Given this list of marker genes CHUK, TRAF2 (TNF receptor associated factor 2), NFKBIA, IKBKB, NFKB1, RELA, IKBKG, here is a description of the gene set: Pathway Definition from KEGG: vFLIP -> TRAF2 -> IKK -> NFKBIA -> NFKB KSHV vFLIP to TNF-NFKB signaling pathway. Pathway ID: N00174. Pathway type: Pathogen. Pathway class: nt06223 TNF signaling. Human Gene Set: KEGG_MEDICUS_PATHOGEN_KSHV_VFLIP_TO_TNF_NFKB_SIGNALING_PATHWAY studied in species Homo sapiens